The following is a description of a gene set: from publication Myllykangas S, Himberg J, Böhling T, Nagy B, Hollmén J, Knuutila S (PMID 16751803) DNA copy number amplifications activate oncogenes and are hallmarks of nearly all advanced tumors. Amplified genes represent attractive targets for therapy, diagnostics and prognostics. To investigate DNA amplifications in different neoplasms, we performed a bibliomics survey using 838 published chromosomal comparative genomic hybridization studies and collected amplification data at chromosome band resolution from more than 4500 cases. Amplification profiles were determined for 73 distinct neoplasms. Neoplasms were clustered according to the amplification profiles, and frequently amplified chromosomal loci (amplification hot spots) were identified using computational modeling. To investigate the site specificity and mechanisms of gene amplifications, colocalization of amplification hot spots, cancer genes, fragile sites, virus integration sites and gene size cohorts were tested in a statistical framework. Amplification-based clustering demonstrated that cancers with similar etiology, cell-of-origin or topographical location have a tendency to obtain convergent amplification profiles. The identified amplification hot spots were colocalized with the known fragile sites, cancer genes and virus integration sites, but global statistical significance could not be ascertained. Large genes were significantly overrepresented on the fragile sites and the reported amplification hot spots. These findings indicate that amplifications are selected in the cancer tissue environment according to the qualitative traits and localization of cancer genes. studied in species Homo sapiens Amplification hot spot 2: colocolized fragile sites and cancer genes in the 12p13-p11.1 region. Human Gene Set: MYLLYKANGAS_AMPLIFICATION_HOT_SPOT_2, and this is the list of marker genes: CCND2, ETV6, KRAS, ZNF384, ERC1